Given this list of marker genes CXCL1, OR2A14, KYNU, ADAP1 (ArfGAP with dual PH domains 1), TBC1D10A, TGFBI, MRTFA, STAT3, NECTIN2, IL4I1, C15orf48, CYP1B1, PPP3R1, AP2B1, RSPRY1, RANBP3L, ANP32CP, TAGLN, RPP14, ANPEP, DTNBP1, PREP, HLX, EXT1, ANXA5, FGR, RHOU, SLC2A1, AQP9, AK4, LSM12 (NCBI Gene Id 124801), H4C4, KLF4, FAM170B (NCBI Gene Id 399567), ABCG4, HAX1, PMS2CL, DDR1 (NCBI Gene Id 780), SOD2, FCGRT, OR12D3, MTMR11, RMRP, SLC43A3, CD200 (NCBI Gene Id 4345), BCL11A, EZH2, IRF2BPL, PLEK, CD14, FTL, ITPRIPL2, CUX1, DNAJB5, SLX9, OSGEP, LYN, THBS1, ITGAX, IL1RN, ZC3H12C, NCF2, SRC, IER3, CTSL, CD63, COL11A2, LYL1, ADM, NR4A3, PLAUR, CDK14, IFNB1 (interferon beta 1), BAG3, RRAD, GET4, NOTCH2NLA, GFOD3P, MASP2, ARMCX1, P2RX4, CCL2, SPRYD3, URB2, SDC4, CD8B, ZNF395, MFSD2A, NUTF2, AGFG2, PLEKHA4, SLC7A5P2, RBM47, here is a description of the gene set: from publication Matsumiya M, Stylianou E, Griffiths K, Lang Z, Meyer J, Harris SA, Rowland R, Minassian AM, Pathan AA, Fletcher H, McShane H (PMID 23844129) A better understanding of the relationships between vaccine, immunogenicity and protection from disease would greatly facilitate vaccine development. Modified vaccinia virus Ankara expressing antigen 85A (MVA85A) is a novel tuberculosis vaccine candidate designed to enhance responses induced by BCG. Antigen-specific interferon-gamma (IFN-gamma) production is greatly enhanced by MVA85A, however the variability between healthy individuals is extensive. In this study we have sought to characterize the early changes in gene expression in humans following vaccination with MVA85A and relate these to long-term immunogenicity. Two days post-vaccination, MVA85A induces a strong interferon and inflammatory response. Separating volunteers into high and low responders on the basis of T cell responses to 85A peptides measured during the trial, an expansion of circulating CD4+ CD25+ Foxp3+ cells is seen in low but not high responders. Additionally, high levels of Toll-like Receptor (TLR) 1 on day of vaccination are associated with an increased response to antigen 85A. In a classification model, combined expression levels of TLR1, TICAM2 and CD14 on day of vaccination and CTLA4 and IL2Ralpha two days post-vaccination can classify high and low responders with over 80% accuracy. Furthermore, administering MVA85A in mice with anti-TLR2 antibodies may abrogate high responses, and neutralising antibodies to TLRs 1, 2 or 6 or HMGB1 decrease CXCL2 production during in vitro stimulation with MVA85A. HMGB1 is released into the supernatant following atimulation with MVA85A and we propose this signal may be the trigger activating the TLR pathway. This study suggests an important role for an endogenous ligand in innate sensing of MVA and demonstrates the importance of pattern recognition receptors and regulatory T cell responses in determining the magnitude of the antigen specific immune response to vaccination with MVA85A in humans. Genes up-regulated in peripheral blood mononuclear cell vaccinated vs control in adults (18-55) (treated in vitro with MVA85A) after exposure to Modified Vaccinia Ankara (MVA) virus vaccine vector, time point 6H Human Gene Set: MATSUMIYA_PBMC_MODIFIED_VACCINIA_ANKARA_VACCINE_AGE_18_55YO_VACCINATED_VS_CONTROL_TREATED_IN_VITRO_WITH_MVA85A_6HR_UP studied in species Homo sapiens